The following is a description of a gene set: studied in species Homo sapiens Human Gene Set: GOBP_MITOCHONDRIAL_ATP_TRANSMEMBRANE_TRANSPORT The process in which ATP is transported across a mitochondrial membrane, into or out of the mitochondrion., and this is the list of marker genes: SLC25A41, SLC25A6, SLC25A5, SLC25A31, ADCY10, SLC25A24 (NCBI Gene Id 92093), SLC25A23, SLC25A4